The following is a description of a gene set: studied in species Homo sapiens Any process that modulates the rate, frequency or extent of inositol phosphate biosynthesis. Inositol phosphate biosynthetic processes are the chemical reactions and pathways resulting in the formation of an inositol phosphate, 1,2,3,4,5,6-cyclohexanehexol, with one or more phosphate groups attached. Human Gene Set: GOBP_REGULATION_OF_INOSITOL_PHOSPHATE_BIOSYNTHETIC_PROCESS, and this is the list of marker genes: SNCA, PTH1R (NCBI Gene Id 5745), PRKG1, P2RY6, LHCGR, PLEK (pleckstrin), AVPR1B, ADCYAP1R1, CD244, PTH (NCBI Gene Id 5741), GPER1, P2RY1, NTSR1